Given this list of marker genes AFG2A, SRPX2, PI4KA, ADGRG1, GRIN2A, SPTAN1, FRRS1L (NCBI Gene Id 23732), here is a description of the gene set: species: Homo sapiens EEG with frontal epileptiform discharges Focal epileptiform EEG discharges recorded in the frontal region. Human Gene Set: HP_EEG_WITH_FRONTAL_EPILEPTIFORM_DISCHARGES